Given this list of marker genes Cr1l, Cd55, Masp1, Foxj1 (forkhead box J1), Cr2, Fcgr2b, Zp3r, Cd59a, Cd46, Serping1, Ptpn6, C4bp, Vsig4, Susd4, Cd59b, A2m, Cd55b, here is a description of the gene set: Mouse Gene Set: GOBP_NEGATIVE_REGULATION_OF_HUMORAL_IMMUNE_RESPONSE studied in species Mus musculus Any process that stops, prevents, or reduces the frequency, rate, or extent of a humoral immune response.